The following is a description of a gene set: Genes predicted to be targets of miRBase v22 microRNA mmu_miR_295_3p in miRDB v6.0 with MirTarget v4 prediction scores > 80 (high confidence targets). Mouse Gene Set: MIR_295_3P from publication Chen Y, Wang X (PMID 31504780) studied in species Mus musculus, and this is the list of marker genes: Cpeb1, Fgf9, Ryr2, Tnfaip1, 2410002F23Rik, Lats2, Asxl3, Zfp362, Smarcc2, Zfp9, Map3k2, Spop, Parp8, Snx8, Rab11a, Prdm8, Usp24, Marchf8, Crim1, Tmub2, Cdkn1a, Reep3, Erap1, Pbx3, Flt1, Ednrb, Mtmr3, Ptprb, Tnrc18, Cnot6l, Pak5, Hs2st1, Smc2, Ppp1r3e, Rab5c, Ism2, Tet1, Prrg1, Zbtb41, Nfya, Micu1 (mitochondrial calcium uptake 1), Unk, F3, Ythdf3, Skida1, Tfap4, Zfp53, Osmr, Rsbn1, Zfp367, Dcaf6, Rictor (NCBI Gene Id 78757), Nr2c1, Epha5, Ankrd17, Rnf150, Hif1an (NCBI Gene Id 77039), Ankrd13c, Mospd2, Mpc1, Ambn, Rgmb, Slc7a2 (NCBI Gene Id 11988), Fndc3a, Rps6ka1 (NCBI Gene Id 230803), Retreg3, Zkscan1, E2f2, Arid4b, Mycn, Zfp800, Tiparp, Cfl2, Pou6f1, Dpp8, Rbl2, Aak1, Rb1cc1, Zbtb43, Mtus1, Hipk3, Vldlr, Elk4, Trim36, Akr1c21, Rest, Txnip, Pde3b, Irf2bp2, Itgb8, Unc80, Coro2b, Slc5a10, Ezh1, Ikzf2, Sar1b (NCBI Gene Id 72945), Unkl, Mllt6, Kmt5b (lysine methyltransferase 5B), Slc49a4, Asf1b, Rnf6 (ring finger protein (C3H2C3 type) 6), Gpc6, Wdr48, Slc6a9, Mylk, Irf9, Ppp1r36, Nufip2, Kmt2a, Btg1, Twf1, Epha2, Rtn1 (reticulon 1), Vmn1r45, Irf2, Rnf216, Krt222, Tmtc1, Kpna2, Pip4k2a (NCBI Gene Id 99429), Uap1, Nfia, Fgd4, Ago1, Suco, Cdca7, Kcnb1, Ube2q2, Taf1, Mier3, Suv39h1 (suppressor of variegation 3-9 1), Hmbox1, Fgd5, Cdk6, Lrat, Miga2, Zfp827, Prdm16 (PR domain containing 16), Synpo2, Slc30a10, Map3k14, Tgfbr2, Tmem123, Lhx6, Malt1, Erc1, Znrf3, Rab22a, Zfp148, App, Gpr158, Ptpn21, Caprin2, Crot, Rbl1, Asap1, Mink1, Hlf (hepatic leukemia factor), Slc7a15, Ddias, E2f7, Rab8b, Npas3 (NCBI Gene Id 71644), Asf1a, Armc8, Sdc1, Zbtb5, E2f5, Lefty1 (left right determination factor 1), Nr2c2, Nfib, Glis3, Sowahc, Plagl2, Trpv6, Adam9, Slc22a23, Dcun1d4, Arhgef17 (NCBI Gene Id 207212), Yod1, Ccnj, Bloc1s5, Cyp26b1, Dcdc2a, Kremen1, R3hdm1, Myrf, Lhx8, Zfyve26, Shc4, Tle4, Cd200, Cnot6, Rassf2, Zbtb11, Ddhd1, Pcdh7, Trip11, Srcin1, Arhgef10, Cluh, Pak2, Kif26b, Ssr1, Ect2, Elavl2, Ash1l, Golga1, Macc1, Marchf11, Ccnd1, Fam168b, Col17a1 (collagen, type XVII, alpha 1), Fzd3, Phc3, Atxn1, Ube2b, Rock2, Mettl21c, Syde1, Slf1, Tapt1, Sf3b1, Prdm4, Ncoa7, Nhsl3, Tiam1, Lefty2, Bcl11b, Clock, Jazf1, Ss18l1, Kat2b, Dgkq, Med12l